The following is a description of a gene set: Human Gene Set: HP_ABNORMAL_MAXILLA_MORPHOLOGY species: Homo sapiens Abnormal maxilla morphology An abnormality of the Maxilla (upper jaw bone)., and this is the list of marker genes: SIN3A, GORAB, DLG1, DLX4, EP300, VPS13B, LTBP3, DCHS1, TCOF1, CDT1, COL5A1, AKT1, ADAMTS10, TINF2, EDA, TGIF1, SF3B4, NECTIN1, FLNB, TMCO1, RIPK4, RIC1, CDH1, CREBBP, PRKAR1A, BGN, RTL1, SIX3, TWIST1, SRCAP, IFIH1, HBB, PDGFRB, MMP2, ERF, ARHGEF38, KIFBP, ORC6, COLEC11, WDR26, CDH11, PQBP1, FGFR3, GRHL3, SMCHD1, COBLL1 (cordon-bleu WH2 repeat protein like 1), EFEMP2, LBR, PRKACA, FGD1, PTEN, RUNX2, ZBTB11, NOP10, DLK1 (NCBI Gene Id 8788), STAMBP, FBN1, RAB3GAP2, ZBTB20, TYMS, ARHGAP29, SETD2, PEX19, FGF3 (fibroblast growth factor 3), NPM1, SMOC1, TERC, USB1, SLC12A6, HRAS, TWIST2, ARSL (arylsulfatase L), GPC4, PYCR2, BMP4, NEK1, NHP2, TUBGCP2, RECQL, POLR1D, FOXP2, POLR1A (NCBI Gene Id 90784), COL11A1, POLR1B, ATP6V1E1, SON, MED12, KCNJ2, ZNF668, EFTUD2, SNRPN, MSX1, PTCH1, GLI2, SKI, ABL1, IL11RA, ORC1, PIK3CA, FHL1, CHSY1, MEG3, B3GLCT, SCARF2 (NCBI Gene Id 91179), FAT4, SMAD4, SLC25A24, UPF3B, TRMT1, EDNRA, FOXC1, KDM5C, NRAS, POLR1C, COL2A1, CDC6, ALX3, PDE4D, UBB, PARN, DKC1, KCNJ5, RPS6KA3, SOX5, ESCO2, AP2M1, TP63, GMNN, SEC23A, UBE3A, PDGFRA, FGFR2, CTSK, BMP2, RTEL1, CTC1, PAX3, SOBP, CDC45, CBFB, ALX1, PITX2, FGFR1, ORC4, MAFB, WRAP53, NFIX, TBC1D2B, SF3B2, ZDHHC9, IRF6, GJA1, TERT, RAB23